The following is a description of a gene set: An anomalous build up of copper (Cu) in the liver. Copper accumulation in liver species: Homo sapiens Human Gene Set: HP_COPPER_ACCUMULATION_IN_LIVER, and this is the list of marker genes: CCDC115, FARS2, SLC51B, TMEM199, SLC30A10